Given this list of marker genes Adam9, Arf6, Has2, Fgf10, Iqsec1, Epb41l4b, Mapre2, Map4k4, Mmp9, Eppk1, Fgf7, Hbegf, Pten, Serpine1, Mtor, here is a description of the gene set: Mouse Gene Set: GOBP_REGULATION_OF_KERATINOCYTE_MIGRATION Any process that modulates the frequency, rate or extent of keratinocyte migration. studied in species Mus musculus